The following is a description of a gene set: Signaling by MRAS-complex mutants Human Gene Set: REACTOME_SIGNALING_BY_MRAS_COMPLEX_MUTANTS studied in species Homo sapiens, and this is the list of marker genes: YWHAB, ARAF, PPP1CC, RAF1, PPP1CB, MRAS, SHOC2, BRAF